Given this list of marker genes POMT1, ADSS1, CHRNB1, AGRN, MUSK, CHRND, MFN2, COL13A1, JAG1, SCN4A, AK9, RAPSN, CHRNA1, CHRNE, FBXO38, DOK7, DYSF, LRP4, here is a description of the gene set: Triceps weakness Human Gene Set: HP_TRICEPS_WEAKNESS studied in species Homo sapiens A lack of strength in the triceps muscle, which normally is responsible for extending (straightening) the elbow and mediating certain shoulder movements.